Given this list of marker genes Ythdc2, Arhgap32 (NCBI Gene Id 70677), Dlc1, Nrg3, Hmgn5, Akirin2, Hivep1, Cibar1, Slco1a6, Bmp2k, Ceacam18, Rab14, Inpp5k, Mark3, Stag2, Arfgef1, Ube2g2, Itgb3bp, Cdc73, Bach2, Neurod6, Cyp3a41a, Pcdh15, Map2, Baalc, Frmd4a, Mdga2, Rp2, Rfx7, Lrrcc1, Rabgap1, Cops7b, Sp5, Dctn4, Nprl3, Zfp281, Zc3h12c, Acer3, Ptpn12, Kmt5a (NCBI Gene Id 98818), Greb1l, Cacna1h, Lhx6, Bicral, Ccdc88a, Hnrnpa1, Cyp3a41b, Snrpd1, Rxra, Cldn10, Lrrtm3, Dnajc19, Pappa, Arid4b, Mob1b, Rap1b, Aldh1l2, Dipk2a, here is a description of the gene set: Mouse Gene Set: MIR_582_3P Genes predicted to be targets of miRBase v22 microRNA mmu_miR_582_3p in miRDB v6.0 with MirTarget v4 prediction scores > 80 (high confidence targets). species: Mus musculus from publication Chen Y, Wang X (PMID 31504780)